The following is a description of a gene set: studied in species Homo sapiens Human Gene Set: chr2q34, and this is the list of marker genes: IDH1, IKZF2, RPL5P8, RNA5SP117, PCED1CP, SPAG16, MYL6BP1, PIKFYVE, ERBB4, ACADL, MIR548F2, VWC2L, MAP2, H3P9, HSPA8P6, CPS1, RPE, MEAF6P1, MTCO1P46, CRYGFP, RPL6P6, PKP4P1, SPAG16-DT, LINC01953, RPSAP27, LANCL1-AS1, LINC01878, ENSG00000310213, IDH1-AS1, KANSL1L-AS1, RNA5SP119, UNC80, RPS27P10, SNAI1P1, MIR4776-2, ARPC1BP1, PTH2R (NCBI Gene Id 5746), MIR4776-1, TPT1P2, MIR4438, MTND2P23, KANSL1L, CPS1-IT1, LANCL1, MYL1, RNA5SP118